Given this list of marker genes Chrna6, Trpm8, Zfp646, Esrrg, Slc45a4, here is a description of the gene set: Genes predicted to be targets of miRBase v22 microRNA mmu_miR_7089_5p in miRDB v6.0 with MirTarget v4 prediction scores > 80 (high confidence targets). from publication Chen Y, Wang X (PMID 31504780) species: Mus musculus Mouse Gene Set: MIR_7089_5P